Given this list of marker genes CSK, DBN1, MTR, NIPSNAP2, VANGL1, STOM, NSFL1C, SLC1A5, RAB7A, LCK, TMEM59, TUBA1B, LAMTOR1, JUP, VAMP3, SLC4A7, OSBPL11, CAV1, ZAP70, ARHGDIG (Rho GDP dissociation inhibitor gamma), DBT, PAK6, TFRC, PAK5, ROCK1, PAK1, WDR11, ARHGDIA, ARHGDIB, PAK4, FAM91A1, PAK2, ROCK2, RALGAPA1, UACA, RHOH, VCP, here is a description of the gene set: Reactome Pathway: RHOH GTPase cycle species: Homo sapiens part of: RHO GTPase cycle RHOH is constitutively bound to GTP and does not require a guanine nucleotide exchange factor (GEF) for activation. RHOH does not possess a GTPase activity, but has been reported to bind to a small number of GTPase activator proteins (GAPs), which possibly function as RHOH effectors. While RHOH is not found in the GDP bound state, GDP dissociation inhibitors (GDIs), still interact with RHOH, presumably affecting its translocation to the site of activity by sequestering it in the cytosol. Similar to RAC2, RHOH expression is also restricted to hematopoietic cells. RHOH function is required for T cell development and RHOH activity is regulated by posttranslational modifications downstream of activated T cell receptor (TCR). Following TCR activation, RhoH is degraded in lysosomes. In blood neutrophils from patients suffering from cystic fibrosis or eosinophils from patients with hypereosinophilic syndromes, an upregulation of RhoH expression has been found. RHOH is subject to mutations and translocations in lymphoma. Mutations in RHOH are associated with abnormal susceptibility to human beta-papillomavirus (beta-HPV) skin infections, which leads to epidermodysplasia verruciformis, a condition characterized by persistent flat warts or beta-HPV associated skin lesions.